Given this list of marker genes SCX, LGR6, TCEAL2, LINC00578, AQP1, SYNPO2, PRUNE2, FGF18, ACTG2, SCARA3, WIF1, SBSPON, GREM2, RAMP1, CKB (creatine kinase B), CLU, XIST, FNDC1, FNBP1, KCNMB1, CLDN1, HHIP, PLXNA4, COL23A1, KCNMA1, here is a description of the gene set: species: Homo sapiens from publication Travaglini KJ, Nabhan AN, Penland L, Sinha R, Gillich A, Sit RV, Chang S, Conley SD, Mori Y, Seita J, Berry GJ, Shrager JB, Metzger RJ, Kuo CS, Neff N, Weissman IL, Quake SR, Krasnow MA (PMID 33208946) Human Gene Set: TRAVAGLINI_LUNG_FIBROMYOCYTE_CELL